Given this list of marker genes Mapk8, Dynll1, here is a description of the gene set: This event has been computationally inferred from an event that has been demonstrated in another species.<p>The inference is based on the homology mapping from PANTHER. Briefly, reactions for which all involved PhysicalEntities (in input, output and catalyst) have a mapped orthologue/paralogue (for complexes at least 75% of components must have a mapping) are inferred to the other species. part of: Activation of BH3-only proteins species: Mus musculus Reactome Pathway: Activation of BIM and translocation to mitochondria electronically inferred by orthology from the curated human pathway